The following is a description of a gene set: species: Mus musculus Catalysis of the reaction: S-adenosyl-L-methionine + histone H3 L-lysine (position 36) = S-adenosyl-L-homocysteine + histone H3 N6-methyl-L-lysine (position 36). This reaction is the addition of a methyl group to the lysine residue at position 36 of the histone H3 protein. Mouse Gene Set: GOMF_HISTONE_H3K36_METHYLTRANSFERASE_ACTIVITY, and this is the list of marker genes: Nsd1, Nsd3, Prdm9, Setd4, Setmar, Smyd3, Setd2, Setd3, Setd5, Smyd2, Ash1l, Smyd5, Nsd2